The following is a description of a gene set: species: Mus musculus T-cell acute lymphoblastic leukemia (T-ALL), unlike other ALL types, is only infrequently associated with chromosomal aberrations, but it was recently shown that most individuals with T-ALL carry activating mutations in the NOTCH1 gene. However, the signaling pathways and target genes responsible for Notch1-induced neoplastic transformation remain undefined. We report here that constitutively active Notch1 activates the NF-kappaB pathway transcriptionally and via the IkappaB kinase (IKK) complex, thereby causing increased expression of several well characterized target genes of NF-kappaB in bone marrow hematopoietic stem cells and progenitors. Our observations demonstrate that the NF-kappaB pathway is highly active in established human T-ALL and that inhibition of the pathway can efficiently restrict tumor growth both in vitro and in vivo. These findings identify NF-kappaB as one of the major mediators of Notch1-induced transformation and suggest that the NF-kappaB pathway is a potential target of future therapies of T-ALL. from publication Vilimas T, Mascarenhas J, Palomero T, Mandal M, Buonamici S, Meng F, Thompson B, Spaulding C, Macaroun S, Alegre ML, Kee BL, Ferrando A, Miele L, Aifantis I (PMID 17173050) Genes up-regulated in bone marrow progenitors by constitutively active NOTCH1. Human Gene Set: VILIMAS_NOTCH1_TARGETS_UP, and this is the list of marker genes: TRAT1, EGR2, CCR7, NFKBIA, HEY1, CX3CL1, CD28, NOTCH3, TOX (NCBI Gene Id 9760), ICAM1, ID2, IL12B, NFKB2, CD3G, LAT, PTCRA, GZMB, CD80, DDR1, CD7, RRAS2, BCL2A1, NRARP, IRF7, BIRC3, GATA3, NFATC1, JUNB, TRAF1, CD69 (CD69 molecule), IL10RA, THY1, CTLA4, DTX1, ZAP70, CD2, LCK, GZMH, CCL5, CD83, CARD11, RAG2, GZMA, CD3D, P2RY10, EGR1, CD74, TNFRSF18, CD86, RAG1, RELB, BIRC2